Given this list of marker genes Hspa14, St13, Hspa1a, Hspa5, Nup214, Rps19bp1, Hikeshi, Nup107, Rpa3, Seh1l, Hspa4, Rae1, Nup155, Nup42, Gsk3b, Nup153, Ndc1, Nup188, Nup205 (nucleoporin 205), Hspa9, Rpa2, Bag2, Hspa1l, Pom121, Hsf1, Nup85, Dnajb6, Hspa4l, Nup93, Dnajc2, Tpr, Bag5, Hspa1b, Nup133, Nup98, Sirt1, Rpa1, Nup54, Nup50, Nup210, Nup88, Hspa2, Nup37, Mapkapk2, Dnajb1 (NCBI Gene Id 81489), Mapk1, Hsph1, Bag1, Nup62, Nup35, Nup58, Mapk3, Hspa12b, Aaas (NCBI Gene Id 223921), Nup43, Ranbp2, Bag3, Hspa12a, Hspa8 (heat shock protein 8), Bag4, Ywhae, Nup160, Hspa13, Sec13, here is a description of the gene set: Mouse Gene Set: REACTOME_REGULATION_OF_HSF1_MEDIATED_HEAT_SHOCK_RESPONSE Regulation of HSF1-mediated heat shock response studied in species Mus musculus